Given this list of marker genes NDRG2, GPR3, CDC16, PRPH, MGST3, MR1, USP2 (ubiquitin specific peptidase 2), RMND5A, PACRG, SDC4, DNAJB8, NKIRAS1, FABP1, HAGH, MKRN3, SLC27A1, SSR3, PLS3, USE1, EMB, TNFAIP8, TUBB2A, NGRN, LXN, MCEE, MXD4, EIF2AK3, SEC23A, CLK4, MAP3K2, FLCN, ANKRD13A, PCSK1, CRIPT, DSPP, BNC1, ASPM, CHRND, PABPC4, RABEP1, NFATC2, AXIN2, CWC15, COPZ2, MYEF2 (NCBI Gene Id 56051), TIMM23, FTSJ3, PARP6, HLA-E, UTP3, POP4, MDM4, CDC26, OPRL1, FAM171A1, GTF2H4, NRDC, ENTPD5, TFEB, EIF5B, CXXC5, HERC1, MXI1, NUS1, PIK3CD, DYRK1A, PPP3CA, ATL2, IFT25, WLS, SLCO3A1, DEGS1, AMH, AKTIP, TRAF4, SSBP2, CFHR2, PTCRA (pre T cell antigen receptor alpha), EMG1, PREB, CD8A, CTLA4, BID, NFATC2IP, ATP13A3, ACADM, EYA2, HOXD13, PSAP, ASXL1, FNBP1, MCM3AP, CDC42SE2, RRAGD, NXN, SIT1 (signaling threshold regulating transmembrane adaptor 1), PHLDB1, TOR2A, OCM2, SELENOH, SOS1, CNN1 (calponin 1), FOXO3, EEF2K, LGI4, BRCA2, NIPSNAP2, EDEM1, LDAH, OAT, TMEM229B, NAP1L4, SMIM20, SMARCD2, RAB4A, HIGD2A, APBB1IP, SMOC1, TAF1A (NCBI Gene Id 9015), CNGA1, ANKRD10, MPP1, MPHOSPH9, TBC1D14, TOLLIP, FBN1, PXK, ELL, RAB7A, RAF1, CREBBP, TRAF1, COMMD6, TIAL1, TBC1D23, SLC39A6, SRRM1, ITPR1, ADCY3, TBCEL, GCOM1, MAPKAPK5, NXPH2 (NCBI Gene Id 11249), GLO1, TRAF5, TXNIP, NSG2, GRIN2D, ADARB1, ZFAND6, PRDX3, BPIFB1, KIF23, BTG3, PMM1, QNG1 (Q-nucleotide N-glycosylase 1), MDFI, NR1D2, MNS1, SLC33A1, CDKN1C, MST1, EMP1, SLC23A1, AGPAT5, CXCL13, MAN1A1, TNFSF10, BCL2L1, MAOA, ITGAV, CHMP2A, CMAS, CLCN3, SLMAP, USP7, PAG1, TMEM179B, SCAF8, CDADC1 (NCBI Gene Id 81602), IL10, UQCC3, XRCC6, MINDY1, ARPC1A, ORC1, RNASEH2B, SNORA7A, FAS, TMEM245, ZHX1, ABCA4, GRAMD2B, SPIN1, GRK2, EIF3J, CBR1, KDM3A, KLF3, WDR55, here is a description of the gene set: Comparison of gene expression changes in CD4+CD8+ thymocytes following engagement of TCR with anti-Valpha or Vbeta antibodies Genes up-regulated in comparison of CD4 CD8 thymocytes stimulated with anti-Valpha2 antibodies versus CD4 CD8 thymocytes stimulated with anti-beta5 antibodies. from publication Niederberger N, Buehler LK, Ampudia J, Gascoigne NR (PMID 15661827) Human Gene Set: GSE1448_ANTI_VALPHA2_VS_VBETA5_DP_THYMOCYTE_UP studied in species Homo sapiens